The following is a description of a gene set: Mouse Gene Set: REACTOME_SIGNALING_BY_ROBO_RECEPTORS studied in species Mus musculus Signaling by ROBO receptors, and this is the list of marker genes: Abl1, Dag1, Pfn1, Uba52rt, Ubc, Usp33, Slit2, Cxcl12, Gpc1, Uba52, Ubb, Enah, Cxcr4, Myo9b, Pfn2, Evl, Vasp, Rps27a, Abl2, Rhoa, Slit3